Given this list of marker genes KMT2C, KMT2B, KMT2A, SETD1B, SETD7, SETD4, SETD1A, KMT2D, here is a description of the gene set: Human Gene Set: GOMF_HISTONE_H3K4_MONOMETHYLTRANSFERASE_ACTIVITY species: Homo sapiens Catalysis of the reaction: L-lysyl4- + S-adenosyl-L-methionine = H+ + N6-methyl-L-lysyl4- + S-adenosyl-L-homocysteine. This reaction is the addition of a single methyl group to the unmethylated lysine residue at position 4 of histone H3, producing histone H3K4me.